Given this list of marker genes MIR604, PRDX2P2, RN7SL825P, RPL7P37 (ribosomal protein L7 pseudogene 37), MTND4P18, RNU6-795P, ENSG00000308646, RNU7-77P, SVIL-AS1, LINC02630, ITGB1, PARD3, RN7SL847P, ZNF33BP1, RPS24P13, ZEB1, DDX10P1, CCNY, RN7SL314P, ZEBTR, ZNF37A, JCAD (NCBI Gene Id 57608), SVIL2P, MTND4LP11, MIR938, PPIAP31, MKNK2P1, ATP6V1G1P4, NIFKP1, SLC9B1P3, ELOBP4, LINC02664, RNU6-847P, RPS12P16, ENSG00000274458, MIR4683 (NCBI Gene Id 100616500), SEPTIN7P9 (NCBI Gene Id 80703), SVIL, ENSG00000285630, FXYD6P2 (FXYD domain containing ion transport regulator 6 pseudogene 2), RPL34P19 (ribosomal protein L34 pseudogene 19), ARHGAP12, CREM, CKS1BP2, CUL2, NAMPTP1, RNU6-598P, ANKRD30A, PLD5P1, PABPC1P12, EEF1A1P39, PTCHD3P1, ZNF33CP, AK3P5, SPTLC1P1, ZNF37CP, ZNF248-AS1, ZNF33A, GJD4 (NCBI Gene Id 219770), NRP1, EIF3LP3, MACORIS, CICP9, ZNF438, TLK2P2, C1DP1, RNU6-1167P, VN1R53P, MTND5P17, CCND3P1, RPL7AP53, RN7SL398P, MIR7162, LINC02628, RNU6-794P, GOLGA2P6, RNU6-193P, HNRNPA1P32, ITGB1-DT, ARL6IP1P2, CCDC7, IATPR, TMEM161BP1 (transmembrane protein 161B pseudogene 1), RNU6-1244P, CCNYL4, HSD17B7P2, RPL23P11, HMGB1P7, ENSG00000223834, RNU6-1118P, EPC1-AS1, RN7SL63P, ENSG00000289616, MTPAP, LINC02644, TACC1P1, PCAT5, DNM1P17, RNU6-908P, ABCD1P2, SS18L2P1, ENSG00000299623, RPL37P18, CCNY-AS1, KIF5B, MIR3611 (NCBI Gene Id 100500890), MTND1P18, EPC1-AS2, LINC00993, ZNF248, FZD8, ZNF25-DT, MAP3K8, RNU6-811P, RPS4XP11, LINC02629, EPC1, ZNF25, ZEB1-AS1, RNA5SP309, CHEK2P5, ACTR3BP5, LINC02635, RN7SL241P, LYZL2, LINC00838, RNU7-22P, PARD3-DT, here is a description of the gene set: Human Gene Set: chr10p11 species: Homo sapiens